The following is a description of a gene set: The directed movement of a protein to a specific location in the endoplasmic reticulum. species: Homo sapiens Human Gene Set: GOBP_ESTABLISHMENT_OF_PROTEIN_LOCALIZATION_TO_ENDOPLASMIC_RETICULUM, and this is the list of marker genes: SEC61A2, HSPA5, GET1, GET4, SRP14, SSR3, SRPRB, EDEM1, SRP9, SRP54, RN7SL1, ZFAND2B, SGTB (small glutamine rich tetratricopeptide repeat co-chaperone beta), SGTA, ZFAND2A, CHMP4A, RN7SL2, TRAM1L1, RAB3GAP1, TTC9-DT, CHMP4B, SNAP25-AS1, BAG6, GLP1R, RN7SL3, SRPRA, SRP68, SEC63, UBL4A, SEC61B, VPS54 (NCBI Gene Id 51542), SPCS1, RYR2, TRAM1, MAN1A1, RAB3GAP2, SRP72, RAB10, BHLHE40-AS1, SEC61G, GJD2-DT, SRP19, ENSG00000283175, HERPUD1, SEC61A1, SPCS3, SEC62, TRAM2, SPCS2